Given this list of marker genes SMARCC1, RPS23, SCAND1, SPG21, RPL26, RPLP0, HNRNPH1, RPL15, RPS12, RPL24 (ribosomal protein L24), CNPY2, PPIB, RPS11, RPL37, COX6A1, NDUFV2, RPL10A, ARPC3, ELOC, COX6B1, SRSF2 (NCBI Gene Id 6427), ALDOA, ACADM, DDX3Y, IPO7, FAU, NDUFA1, MAGT1, LBHD1, RPS27, RPL18A (ribosomal protein L18a), PSMB7, ERP29, RPS10, EIF1, DAD1, XPO1, WDR83, HSPA8, RPS24, CTNNA1, RACK1, SDHB, RPS27A, HNRNPR, IMPDH2, RPS21, RPL6, BLOC1S1, RAMAC, CANX, RPS18, CDC37, RPS28 (ribosomal protein S28), RAB10, PSMC2, PSMB3, RPSA, HMGB1, ATP5MJ, ATP5PO, MTPN, BCAP31, RPS25, SOD1, SRP9, COX7B, TMEM147, RPS20, EEF1G, IMP3, HSPB1, NDUFB7, RRAGA, HNRNPA1, PSMA3, KPNA2, NAP1L1, KPNA4, SNRPD2, EIF3C, NME4, PSMD8, SNRPB, DNAJA1, GTF2A2, LSM5, RPL27A, ATP6V0E1, EIF3F, RPS4X, SSB, TMEM59, PRDX5, RPL17, RPL38, HIGD2A, UQCRC2, FKBP4, CHMP2A, MDH1, RPL35, ECI1, BZW1, EXOSC7, RPL28, NDUFAB1, GRHPR, PSMA1, RAN, EIF4H, NDUFS5, UBL5, NDUFB1, UQCR11, EEF1A2, RPL19, EIF3H, COX7A2, STRAP, ATN1, CARS1, EIF3I, ADIPOR2, CDIPT, EEF1B2, POLR2G, MRPS18B, MRPL30, RPL8, TGIF1, SSBP1, YBX1, MRPL21, OAT, SNRPG, HLA-C, RPS17, RPS29, COX5B, MOSPD1, RETNLB, RPS15, PFDN5, SNRPB2, RPL39, ZNHIT1, VDAC1, STMN1, SUB1, BBLN, PSMD10, PRDX6, MYL12A, ZFAND6, NPM1, COX7C, TIPIN, PRELID1, COX6C, RPL7A, RPL14, EIF3D, UQCRB, SNRPE, EEF1A1, RAP1B, PSMA4, SEC13, MYL12B, RPLP2, EEF2, PSMA2, RRP9, KRT6A, CIAO2A, YME1L1, RBM3, UQCRH, HSBP1, DAP3, RPS13, RPS8, CCT3, CD63, HINT1, PLEKHF2, RPL11, RPL3, SRSF6, PHB2, RPL21, PNP, RPL10, PIH1D1, RPL27, PPP1CC, SRSF7, RNASEH2C, GADD45G, DAP, RPL36AL, NDUFAF7, EEF1D, RPLP1, UQCRQ, B2M, UXT, NACA, NCL, RPS3 (ribosomal protein S3), RPS3A, LDHB, ZNF525, RPS15A, RPL34, NSA2, PLA2G2A, RPL4, P4HB, RPS27L, CDC40, DNPH1, RSL24D1, ALDH9A1, RPL35A, EIF3M, EIF4A3, RPL12, SRPRA, RBMS1, TMSB4X, CCT8, TIMMDC1, SEC61B, PSMB5, CBX6 (chromobox 6), RPL36A, C1QBP, SATB1, RPL5, PCBP1, PTMA, ATP5IF1, RPS19, CDC123, SRSF11, PSMB1, PSMD6, HNRNPH2, RPL32, MSI1, RPL23A, SERP1, TSPYL1, RPS16, ARHGDIA, TRA2B (NCBI Gene Id 6434), ELOB, LDHA, RPL23, PFN1, SNRPF, MRPL33, YWHAG, RPL13A, ACAA1, SEMG2, GNAS, RAB5C, IER2, CARD19, APRT, PKM, ECH1, PRDX1, GLB1, ATP5ME, RBCK1, RPS2, KHDRBS1, PSMD1, EIF3G (NCBI Gene Id 9606), RPL31, RPL7, NDUFA13, RAB11A, EIF4B, EIF4A1, STAU1, PPA1, ATP5MC2, GNG10, RBM4, FKBP2, RPS9, TUBA3C, SRP14, TMED2, PABPC1, PSMB4, EIF3E, IDH1, EIF5A, GSN, SRP19, RPL13, RPL18, UBA52, RPL9, TPT1, DYNLL1, BTF3, CAPNS1, RPS5, RPL29, NDUFS4, PCBP2, NME2, RPS4Y1, here is a description of the gene set: species: Homo sapiens Human Gene Set: MODULE_83 Genes in the cancer module 83.